The following is a description of a gene set: Hallux varus species: Homo sapiens Human Gene Set: HP_HALLUX_VARUS Medial deviation of the great toe owing to a deformity of the great toe joint causing the hallux to deviate medially., and this is the list of marker genes: FGFR2, CHST11, HOXA13, FGFR1, FGF9